Given this list of marker genes ELK1, JAK1 (NCBI Gene Id 3716), IFNG, PLCG1, ITGAV, GRB2, RAPGEF1, SOS1, CAV1, PIK3R1, CAV3, SRF, SHC1, SHF, PDGFRA, CRKL, PIK3CA, CRK, CSNK2A1, FOS, JUN, SHB, here is a description of the gene set: from publication Schaefer CF, Anthony K, Krupa S, Buchoff J, Day M, Hannay T, Buetow KH (PMID 18832364) studied in species Homo sapiens PDGFR-alpha signaling pathway Human Gene Set: PID_PDGFRA_PATHWAY